The following is a description of a gene set: Mouse Gene Set: LEE_AGING_NEOCORTEX_UP Upregulated in the neocortex of aged adult mice (30-month) vs young adult (5-month) species: Mus musculus from publication Lee CK, Weindruch R, Prolla TA (PMID 10888876) Ageing of the brain leads to impairments in cognitive and motor skills, and is the major risk factor for several common neurological disorders such as Alzheimer disease (AD) and Parkinson disease (PD). Recent studies suggest that normal brain ageing is associated with subtle morphological and functional alterations in specific neuronal circuits, as opposed to large-scale neuronal loss. In fact, ageing of the central nervous system in diverse mammalian species shares many features, such as atrophy of pyramidal neurons, synaptic atrophy, decrease of striatal dopamine receptors, accumulation of fluorescent pigments, cytoskeletal abnormalities, and reactive astrocytes and microglia. To provide the first global analysis of brain ageing at the molecular level, we used oligonucleotide arrays representing genes to determine the gene-expression profile of the ageing neocortex and cerebellum in mice. Ageing resulted in a gene-expression profile indicative of an inflammatory response, oxidative stress and reduced neurotrophic support in both brain regions. At the transcriptional level, brain ageing in mice displays parallels with human neurodegenerative disorders. Caloric restriction, which retards the ageing process in mammals, selectively attenuated the age-associated induction of genes encoding inflammatory and stress responses., and this is the list of marker genes: M6pr, Psat1, C4b, Sec23b, Avp, Mpeg1, Stxbp3, Csnk1g2, Cd9, Sat1 (spermidine/spermine N1-acetyl transferase 1, NCBI Gene Id 20229), Cmpk1, Csnk1d, Spp1 (secreted phosphoprotein 1), Dhx15, Lgals3bp, Icam2, Gfap, Ddit3, 1700018L02Rik, Myl12a, Itih3, Eef2, Ccl21b, Lcat, Stom, Tubb5, Ptgs1, Dnajb13, Phb1, Nr4a1, Rab4a, Ndrg1, Mag, Cd68, Ifi27, Rufy1, C1qc, Apod, Oxt, Akt2, Dnaja4, Dlg1, Rhog, Ctsz, Ubc, Ctnnb1, Cryab (NCBI Gene Id 12955), B2m, Rab14, Rraga, Kcna1, Gadd45a, Fos, Hsd17b12, Vps72, P4ha1, Sema4b (sema domain, immunoglobulin domain (Ig), transmembrane domain (TM) and short cytoplasmic domain, (semaphorin) 4B), Cyb561, Junb, Fxyd6, Aldoc, Ppp1r2, Set, C1qa, S100a10, Zfp975, Ctsd, Lamb1, Vim, Cox8b, Dnah8, Ppp2r5c, Atp1b3, Napa, Ctss, Vamp1, Vegfa, Wwox, Nub1